The following is a description of a gene set: from publication Chaussabel D, Semnani RT, McDowell MA, Sacks D, Sher A, Nutman TB (PMID 12663451) Genes down-regulated in comparison of macrophages exposed to T. gondii versus macrophages exposed to M. tuberculosis. Monocyte-derived dendritic cells (DC) and macrophages (MΦ) generated in vitro from the same individual blood donors were exposed to five different pathogens, and gene expression profiles were assessed by microarray analysis. Responses to Mycobacterium tuberculosis and to phylogenetically distinct protozoan (Leishmania major, L. donovani, Toxoplasma gondii) and helminth (Brugia malayi) parasites were examined, each of which produces chronic infections in humans yet vary considerably in the nature of the immune responses they trigger. species: Homo sapiens Human Gene Set: GSE360_T_GONDII_VS_M_TUBERCULOSIS_MAC_DN, and this is the list of marker genes: PSMB2, INPP4B, SPINK4, AIF1, PPM1H, DSCR4, RFXAP, ST8SIA4, IL15RA, REM1, ACOX1, SMYD5, ZNF507, ACSL1, PPP1R3D, CEACAM7, CLASP1 (cytoplasmic linker associated protein 1), ACVR1, NFKB2, CD163, GLUL, PSME2, CA12, IL15, ATP5F1B, SLC4A7, B3GNTL1, PTPRCAP, ABCD4, PPP2R2B, GBP2, PSMA5, PLPP2, CTDSP2 (CTD small phosphatase 2), NUP133, STUM, STAT4, CXCL13, DLEC1, PDGFA, MUC6, CCSER2, IL1RAP, STEAP1, IBTK, PLAU, CAPN7, PARP2, STXBP2, MCC, PTGS2, ACP2, TRIAP1, IREB2 (NCBI Gene Id 3658), FCGR3A, ZFP37, ARHGAP5, FKBP1A, BCL2L2, ZNF629, ELP1, MIR124-1HG, PENK, CDKN1A, IL6, CST5, RAB4B, TLR2, PPP1R13B, CCL4, SCN1B, CREB3L1, INPP5B, TLK2, OVOL3, NTNG1, NBR1, HTR1E, VEGFA, TM4SF1, LIMK2, KCNMA1, PTPN1, TSNAX, PLA2G1B, ZFP36, TLN2, ATOX1, HOXD9, TNFAIP6, IDO1, N4BP3, FSTL1, SAPCD1, SLC39A8, ETV6, CCDC22, BLVRA, DMXL1, IRF6, IL1B, SDS, VPS45, CXCL2, ZNHIT1, ZNF268, MARCO, ZNF185 (NCBI Gene Id 7739), OPTN, ADCY8, ZNF189, TNFAIP2, BST1, ZNF273, CROT, DTNB, ASTN1, AP1B1, HMBS, GTF2E1, PIP, NOL4, SIK1, PSG9, TXNIP, ARSB, VCAN, MS4A1, SLC22A4, IQSEC2, SBNO2, BCL2L1, UCP2, ADA, SPHK2, CFB, SLC31A2, ZNF92, LAMB3, HTRA1, PADI2, STOM, DIPK1A, ETHE1, CDH11, PBX2, VPS9D1, SEC22B, SPAG1, AFM (afamin), UFD1, FABP3, CCL5, PYGM, DCHS1, GPR12, CCN2, AMPD2, CYP27B1, GIP, INTS3, BMP2K, IFITM1, IRF1, UBE2L6, NDP, REG1CP (regenerating family member 1 gamma, pseudogene), TRPC4AP, H1-2, PTGES, RASSF8, POU3F2, CXCL5, GOLIM4, GRPEL1, CCL19, CXCL1, CA5B, COASY, RHOA, FETUB, DSC1, VAMP5, KCNE1, SLC25A44, ARF3, ERC1, SCN9A, ARR3, NPY5R, CCL20 (C-C motif chemokine ligand 20), AMHR2, SNRPA1, HCG4B, MTF1, H2BC11 (H2B clustered histone 11), NISCH (NCBI Gene Id 11188), EDDM3A